The following is a description of a gene set: Genes predicted to be targets of miRBase v22 microRNA mmu_miR_3062_3p in miRDB v6.0 with MirTarget v4 prediction scores > 80 (high confidence targets). species: Mus musculus Mouse Gene Set: MIR_3062_3P from publication Chen Y, Wang X (PMID 31504780), and this is the list of marker genes: Gcsam, Shisal1, Capn5, Itga9, Fgf9, Clip3, Fut8 (fucosyltransferase 8), G3bp2, Ankfn1, Foxo4, Phf19, R3hdm4, Wnt9b (NCBI Gene Id 22412), Stag3, Spata31d1c, Cdkl3, Slc12a9, Syk, Vegfa, Grhl2, Mlxip, Sox13 (SRY (sex determining region Y)-box 13), Cpne7, Ikzf4, Ifnlr1, Ccnq, Acot7, Lrch4, Astl, Igsf9b, Dchs1, Mecom, Spx, Pip5k1c, Zfp629, Usp5, Gnao1, Slc12a5, Celf5, Smarca1, Zfp207, Tmem179, Slc7a1, Plxna1, 4930523C07Rik, Cdc37 (NCBI Gene Id 12539), Bcl2l13, Rab5b, Prl5a1, Sfxn5, Ambn, Fnbp1, Pacsin1, Map3k9 (NCBI Gene Id 338372), Nos1, Tarbp1, Gpr173, Slc4a8, Zfp39, Ankrd63, Dlg3, Hipk1, Tram1, Cic, Sdc3, Mmp24, Npbwr1, Atcay, Sox6, Cbx5, Rbms3, Rai14, Aoc3, Plxnd1, Ascl4, Smg7, L3mbtl4, Foxn1, Anks1, Ak5 (NCBI Gene Id 229949), Spata7, Sypl2, Echdc1, Sema4c, Slc6a11, Tsr2 (TSR2 20S rRNA accumulation), Fgfr2, Prrc2b, Kbtbd11, Cflar, Dtx4, Tmem25, Pigm, Cwc15, Pdxp, Fam168a, Vil1, Krtap4-7, Scn7a, Gnal, Fosl2, Nfic, Cplx2, Iffo2, Ptger4, Csgalnact2